The following is a description of a gene set: Any process that modulates the rate, frequency or extent of a necroptotic process, a necrotic cell death process that results from the activation of endogenous cellular processes, such as signaling involving death domain receptors or Toll-like receptors. Mouse Gene Set: GOBP_REGULATION_OF_NECROPTOTIC_PROCESS species: Mus musculus, and this is the list of marker genes: Casp8, Aifm1, Parp1, Cyld, Birc3, Ybx3, Cflar, Ripk3, Spata2, Birc2, Rnf31, Adprs, Fzd9, Peli1, Fadd, Casp6, Slc25a4, Ripk1, Mutyh, Bok, Zbp1, Cav1, Rbck1, Map3k7 (mitogen-activated protein kinase kinase kinase 7)